The following is a description of a gene set: Enables the transfer of a solute or solutes from one side of a membrane to the other according to the reaction: ATP + H2O + cation(out) = ADP + phosphate + cation(in). Mouse Gene Set: GOMF_ATPASE_COUPLED_MONOATOMIC_CATION_TRANSMEMBRANE_TRANSPORTER_ACTIVITY studied in species Mus musculus, and this is the list of marker genes: Atp5f1b, Atp13a5, Atp13a4, Atp6v1g1, Atp1a4 (ATPase, Na+/K+ transporting, alpha 4 polypeptide), Atp2a2, Atp6v0e, Atp2a3, Tmem94, Atp1b3, Atp6v1h, Atp6v0c, Atp6v1b2, Atp6v0b, Abcc8, Atp2b1, Atp5mg, Atp6v0a1, Atp1a2, Atp1a1, Atp4a, Atp1b1, Kcnj8, Atp2b2 (NCBI Gene Id 22426), Atp2a1, Atp6v0a2, Abcc9, Atp2b3, Anxa5, Atp2b4, Atp6v1f, Atp6v1d, Atp6v1a, Atp6v0e2, Atp5f1e, Atp6v1e2, Atp2c2, Atp2c1, Atp6v0d2, Cpox, Atp6v1g2, Atp13a2, Atp13a3, Atp6v1c2, Atp4b, Atp6v1e1, Atp1b2, Atp1a3, Atp6v1g3, Kcnj11, Atp6v0a4, Atp12a, Atp13a1, Atp7a, Atp6v0d1, Atp7b, Atp6v1c1, Atp6v1b1